Given this list of marker genes BGN, PXN, ITGA5, AHR, HEY1, LUZP1, CD9, MYLK, SHE, ETS2, STC1, HEG1, PIM3, FKBP1A, UNC5B, SOCS3, GNG11, DAB2, SRGN, RAI14, PRCP, COL13A1, BMPR2, GASK1B, PXDN (NCBI Gene Id 7837), REST, PITPNC1, EMP1, IGFBP7, MADCAM1, NLRC3, LDHB, IL4R, CEBPG, LAMA4, FZD4, TM4SF1, RASGRP3, PTMA, FHOD1, FABP5, SERPINE1, VWA1, NOTCH4 (notch receptor 4), ANKRD11, VWF, CD59, RAB31, COL5A3, GBP4, ESAM, SNAI1, JAG1 (jagged canonical Notch ligand 1), LMO2, SLCO2A1, MYH9, MLEC, RCC2, P2RY6, EFNB2, NOL4L, ANGPTL2, SLC7A11, SMAD7, ARHGDIB, SMAD6, MARCKSL1, F2R, PLPP3 (NCBI Gene Id 8613), CALCRL, CXCL12, CLEC14A, SULF2, ESM1, SOX4, PTPRB, HDAC7, TIE1, UTRN, TGFBR2, GPR4, SOX18, KLHL24, SYNM, EMCN (NCBI Gene Id 51705), ITPRIPL2, LRRC8C, CLIC4, MSX1, PPP1R18, HLX, LATS2, STING1, ID3, NID1 (nidogen 1), INSR (insulin receptor), JAM3 (junctional adhesion molecule 3), ADAMTS4, PRDM1, CTNNA1, CD34, SPTBN1, ID1, BCL6B, GRB10 (growth factor receptor bound protein 10), RHOJ, IFITM1, EFNA1 (NCBI Gene Id 1942), HPCAL1, MLLT1, ADGRL4, ARHGAP23, QKI, PTMAP11, FSTL1, MMP1, LGALS1, RFLNB, CFL1, MYL12B, TM4SF18, FSCN1, YES1, SPRED1, PFKP, ADGRL2, LAMC1, NEDD9, DHRS3 (dehydrogenase/reductase 3), IFITM2 (NCBI Gene Id 10581, interferon induced transmembrane protein 2), ACE, BNIP2, PTPRE, ARPC2, NQO1, CBL, RGCC, IGFBP4, TBC1D8, DOCK4, FLT4, PEA15, TUBB6, PREX1, ARHGAP31, IL6ST, CYP1B1, SNAP23, ARHGEF12, CLIC2, IFI16, WDR1, DIPK2B, NRP1, SEC14L1 (NCBI Gene Id 6397), ARHGAP29, PGM2L1, SPRY4, JAK1, SLC12A7, UBE2J1, MEF2C, ANKRD50, OLFML2A, A2M, MYCN, KBTBD2, LXN, PASK, SEMA3G, GIMAP4, RASA4, COL4A2, GMFG, PECAM1, NRP2, ANGPT2, LAMB1, KLF13, PTPN12, CDH5, TSC22D1, ECSCR, ITGA1, DENND11, ZFP36L2, RBMS1, CD81, HLA-E, PODXL, SPARC, CYP1A1, GIMAP8, MPRIP, ST8SIA4, SPARCL1, CYYR1, MCAM, RB1, ERBIN, LRRC32, COL15A1, HTRA3, MECOM, IFITM3, SASH1, PNP, TP53INP2, EPAS1, TMSB10, LPAR6, RAPGEF1, SPG7, DGKD, TP53I11, ETS1, TCIM, TBC1D1, MEF2A, SPON2, SNRK, SERPINH1, PRSS23, MCF2L, RIPOR1, LHFPL2, SH3KBP1, NOTCH1, DPYSL3, RAPGEF4, CTNNB1, ADAMTS9, PKP4, F2RL3, RELL1, SLC2A3, LDB2, ELK3, CAV1, PCAT19, PLEKHO1, PLEKHG1, CHSY1, CSF2RB, PMEPA1, HOXB6, SWAP70, HMGB1, PDGFA, GPX1, CCND1 (NCBI Gene Id 893), ATAD3C, MACF1, SLC44A2, HLA-B, HK1, TMEM204, EHD4, WWTR1, EFNB3, SGK1, LIMS1, PLXNA2, RILPL2, ZNF532, APP, DLC1, UACA, ACVRL1, ITGAV, CBLB (NCBI Gene Id 868), SNTB2, APLNR, VASH1, FAM43A, SELE, RDX, EXOC3L2, MSN, PDGFB, SLC38A2, CDR2L, ITPRIP, HIP1, LHFPL6, MRTFB, PGM2, BDKRB2, FCN3, ABI3, RGS5, RSU1, MMP2, LIFR, S100A13, CXCR4, ADGRF5, VIM, FMNL3, SH2D3C, THBD, KCTD20, ITGA2, CD36, PELO, LRRC8A, COL4A1, TSPAN14, JUP, NRARP, RAMP2, SKAP2, MMRN2, MYCT1, SHANK3, TMEM47, ERG, IFI27, FRMD4A, ECE1, ICAM1, LBH, ATP1B3, SH2B3 (SH2B adaptor protein 3), PLVAP, STOM, TEK, NKX2-3, CAVIN1, ZEB1, ROBO4, TCF4, AFAP1L1, UPP1, NOVA2, CD93, CDK2AP1, SLC26A2, ZNF503, UXS1, DUSP6, ADGRG1, DAB2IP, GAB1, DKK3, PDE2A, CEP170, FLT1, THBS1, CYGB, RAP1A, GATA2, HTRA1 (HtrA serine peptidase 1), TGFBR1, SYNPO (NCBI Gene Id 11346), GARRE1, KCNN3, FRMD8 (FERM domain containing 8), CDC37, ID2 (NCBI Gene Id 3398), GIMAP7, KDR, here is a description of the gene set: from publication Muraro MJ, Dharmadhikari G, Grün D, Groen N, Dielen T, Jansen E, van Gurp L, Engelse MA, Carlotti F, de Koning EJ, van Oudenaarden A (PMID 27693023) Human Gene Set: MURARO_PANCREAS_ENDOTHELIAL_CELL studied in species Homo sapiens